Given this list of marker genes 18S rRNA, FBL, RPL32, RPS29, RPL4, NOC4L, RPS13, RPL36A, RPS28, RPL34, RPL6, PELP1, 5.8S rRNA, RNA45S5, RPL24, EXOSC5, RIOK1, RRP9, BOP1, RPL7A, DCAF13, XRN2, RPL36, RPS15A, MPHOSPH10, RPL3L, RPS25, UTP14A, CSNK1E, NCL, EBNA1BP2, WDR3, RPL23, RPS6, DHX37, EXOSC10, TBL3, RPL19, BUD23, RPL15, WDR43, UTP25, WDR46, RPL10L (NCBI Gene Id 140801), RPL12, RPS4Y2, RPL5, NOL12, SNORD3A, RPL17, RPSA, CSNK1D, RPL27A, LTV1, RPS26, RIOK3, RPS4Y1, RPL31, RPL7, EXOSC7, PES1, RPP25, EXOSC4, RPL27, WDR36, RPLP2, NIP7, FCF1, TEX10, RPS2, PDCD11, RPP14, RRP36, RPL10, 5S rRNA, HEATR1, RPL29 (ribosomal protein L29), RPS27L, WDR75, PWP2, RPS11, RPS23, RPL35, UTP18, IMP4, RPS27A, RPP40 (ribonuclease P/MRP subunit p40), RPS3, RBM28, RPL11, NOP14, RPS4X, RPP30, FAU, UBA52, RPL39, RPL39L, RPLP1, RPS21, DDX49, RRP7A, UTP3, SENP3, TSR1, RPL26L1, C1D, RPS10, EXOSC3, EXOSC8, DDX47, WDR18, RPL37, DIS3, IMP3, RPS14, RPL9, RPS27, RIOK2, MPHOSPH6, RPL41, RPS17, RPP38, 28S rRNA, NOB1, UTP4, RPL18, LAS1L, UTP14C, RPL13, RPS8, MTREX, RPL26, RPS18, RPL35A, BMS1, NOP58, RPL36AL, RPS9, RPLP0, SNU13, DDX21, EXOSC2, RPL18A, EXOSC1, RPS15, PNO1, UTP15 (UTP15 small subunit processome component), RPS19, RPL14, EXOSC9 (exosome component 9), RRP1, RPL28, GNL3, RPL38, UTP20, FTSJ3, ERI1, RPS12, EMG1, KRR1, NOL6, NOL11, RPL21, RPL23A, RPS3A, RPP21, WDR12, RPL22, ISG20L2, RPS20, UTP6, RPL8, RPL13A, RPS7, NOL9, RCL1, RPS5, RPL37A, RPL10A, RPS16, DDX52, RPL22L1, EXOSC6, RPL3, RPS24, BYSL, RPL30, UTP11, NOP56, here is a description of the gene set: part of: rRNA processing in the nucleus and cytosol species: Homo sapiens Reactome Pathway: Major pathway of rRNA processing in the nucleolus and cytosol In humans, a 47S precursor rRNA (pre-rRNA) is transcribed by RNA polymerase I from rRNA-encoding genes (rDNA) at the boundary of the fibrillar center and the dense fibrillar components of the nucleolus. The 47S precursor is processed over the course of about 5-8 minutes by endoribonucleases and exoribonucleases to yield the 28S rRNA and 5.8S rRNA of the 60S subunit and the 18S rRNA of the 40S subunit. As the pre-rRNA is being transcribed, a large protein complex, the small subunit (SSU) processome, assembles in the region of the 18S rRNA sequence, forming terminal knobs on the pre-rRNA. The SSU processome contains both ribosomal proteins of the small subunit and processing factors which process the pre-rRNA and modify nucleotides. Through addition of subunits the SSU processome appears to be converted into the larger 90S pre-ribosome (inferred from yeast in Grandi et al. 2002). An analogous large subunit processome (LSU) assembles in the region of the 28S rRNA, however the LSU is less well characterized (inferred from yeast in McCann et al. 2015).<br>Following cleavage of the pre-rRNA within internal transcribed spacer 1 (ITS1), the pre-ribosomal particle separates into a pre-60S subunit and a pre-40S subunit in the nucleolus. The pre-60S and pre-40S ribosomal particles are then exported from the nucleus to the cytoplasm where the processing factors dissociate and recycle back to the nucleus<br>Nuclease digestions of the 47S pre-rRNA can follow several paths. In the major pathway, the ends of the 47S pre-rRNA are trimmed to yield the 45S pre-rRNA. Digestion at site 2 (also called site 2b in mouse, see Henras et al. 2015 for nomenclature) cleaves the 45S pre-rRNA to yield the 30S pre-rRNA containing the 18S rRNA of the small subunit and the 32S pre-rRNA containing the 5.8S rRNA and the 28S rRNA of the large subunit. The 32S pre-rRNA is digested in the nucleus to yield the 5.8S rRNA and the 28S rRNA while the 30S pre-rRNA is digested in the nucleus to yield the 18SE pre-rRNA which is then processed in the nucleus and cytosol to yield the 18S rRNA. At least 286 human proteins, 74 of which have no yeast homolog, are required for efficient processing of pre-rRNA in the nucleus